Given this list of marker genes Axin2, Sub1, Wt1, Slc16a13, Vash2, Kansl3, Pthlh, Gemin5, Amotl2, Ppp1r18, Ep300, Svopl, Ythdf3, Yars1, Slu7, Pfkfb3, Zfp763, Rdh13, Fam120a (family with sequence similarity 120, member A), Atxn7, Rai14, Cbx6, Map3k1, Klhl31 (NCBI Gene Id 320711), Lars2, Gucy1a2, Arih1, Ube2e3, Slitrk6, Sybu, Clcn3, Sec22a, Tcl1, Gpm6a, Plxdc2, Prl7a2, Vta1, Esp16, Prr12, Slco3a1, Usp24, Ints6, Zeb2, Bicd2, Col4a5, Cul2, Dnajb4, Pes1, Sde2, Nudcd1, Cachd1, Gprasp2, Dach1, Vapb, Rnf217, Zp3r, Enc1, Asph, Map3k2, Trim39, Esp15, Sh3glb1, Srpk2, Peli1, Cpd, Atad5, Satb2, Phka1, Eomes, Foxs1, Nr2f2, Gpr158, Azi2, Spock3, Sim1, Hoxb7, Klb, Hoxa11, Prkar2a, Tnrc6b, Tenm4, Sec16b, Il12a, Fign, Dtna, Pml, Ppp3cb, Atxn1, Aplnr, Slc5a12, Kifap3, Fstl4, Cggbp1, Eya1, here is a description of the gene set: Mouse Gene Set: MIR_7046_3P from publication Chen Y, Wang X (PMID 31504780) Genes predicted to be targets of miRBase v22 microRNA mmu_miR_7046_3p in miRDB v6.0 with MirTarget v4 prediction scores > 80 (high confidence targets). species: Mus musculus